The following is a description of a gene set: DC-SIGN is a C-type lectin expressed by dendritic cells (DCs) that binds HIV-1, sequestering it within multivesicular bodies to facilitate transmission to CD4+ T cells. Here we characterize the molecular basis of signalling through DC-SIGN by large-scale gene expression profiling and phosphoproteome analysis. Solitary DC-SIGN activation leads to a phenotypically disparate transcriptional program from Toll-like receptor (TLR) triggering with downregulation of MHC II, CD86, and interferon response genes and with induction of the TLR negative regulator ATF3. Phosphoproteome analysis reveals DC-SIGN signals through the leukemia-associated Rho guanine nucleotide exchange factor (LARG) to induce Rho activity. This LARG activation also occurs on DC HIV exposure and is required for effective HIV viral synapse formation. Taken together HIV mediated DC-SIGN signalling provides a mechanism by which HIV evades the immune response yet induces viral spread. from publication Hodges A, Sharrocks K, Edelmann M, Baban D, Moris A, Schwartz O, Drakesmith H, Davies K, Kessler B, McMichael A, Simmons A (PMID 17496896) Human Gene Set: GSE6090_UNSTIM_VS_DC_SIGN_STIM_DC_UP Genes up-regulated in dendritic cells: control versus stimulated with anti-CD209 antibody. studied in species Homo sapiens, and this is the list of marker genes: ABCA12, CLPB, FOXRED1, OXSR1, ALG14, DCTN5, MIA2, SRXN1, EIF2B3, GPN1, VPS41, MPPED2, PTS, SFXN1, RBM7, SCMH1, SMURF2, RWDD2B, SMCO4, WDR77, PIGX, RYK, CHAC2, MAOA, INTS4, SERPINF1, UBA3, TIRAP, GABPA, BEND6, PRSS12, VPS11, SCFD2, LIMS1, RNASEH2A, SPCS3, CUX1, ELF2, PCIF1, GTF2E2, ORMDL1, MED30, ANK2, STRADA, GNPAT, USP4, POLR1F, RHBDD1, BCAS2, PCDHB9, RACK1, HSF2, RNF24, LRRC40, TMED2, MIR28, TULP3, VCL, TPRKB, PDK1, COPS5, N6AMT1, DUSP6, TTC27, VPS35, XRCC5, ECI2, YARS1, PCTP (NCBI Gene Id 94001), XPO5, WDR45B, ILK, ALDH18A1, FIZ1, PRDX4, ELMOD2, KPNA1, PRRG4, TMEM126B, MYO1E, IFT56, UCHL5, TBC1D8B, CLN5, TUT1, HASPIN, STAT6, RACGAP1, TMEM170B, PPP3CA, PIP4K2B, BRI3BP, DTL, RFC2, TMEM107, GALNT1, TDP1, SUZ12, LACTB2, RGS12, NAXD, LRRN4CL, AMMECR1, GEN1, SMYD5, GOLIM4, MCM3, HINT3, EIF4ENIF1, CNOT7, BMS1, PCDHB12 (NCBI Gene Id 56124), EXOSC8, CDYL, MECR, CTNND1, ZNF106, PGAP3, HEXIM1, ALG11, EPHX4, ANAPC5, ARMC1, SMAD2, CREBBP, SPECC1, PSMD7, CBX5, JMY, AGPAT5, ACMSD, WDR12, PHKB, ST7, XYLB, BBS9, YEATS4, GMPPA, KIF5B, MMGT1, SDHA, LSS (lanosterol synthase), NEK2, TDP2, TPX2, PRMT3 (protein arginine methyltransferase 3), RPL18, DUSP4, RCL1, DNAJB11, CAMLG, FZD1, COMMD2, SOX11 (NCBI Gene Id 6664), RDH11, ACO1, WBP1, BTD, FRMD3, TSEN15, RENBP (NCBI Gene Id 5973), NSF, FAM185A, GTF2E1, PTPN11 (NCBI Gene Id 84990)